The following is a description of a gene set: studied in species Homo sapiens Genes predicted to be targets of miRBase v22 microRNA hsa-miR-98-5p in miRDB v6.0 with MirTarget v4 prediction scores > 80 (high confidence targets). from publication Chen Y, Wang X (PMID 31504780) Human Gene Set: MIR98_5P, and this is the list of marker genes: NME6, SALL3, FAXC, CLCN5, SLC22A23, LIPH, NIPAL4, PBX3, TMOD2, STRBP, CPEB2, TMPPE, ITGB3, MYCN, E2F6, RGS16, ZCCHC9, CCNJ, TGFBR3, CLP1, ABL2, ERCC4, ATOSB, SENP5 (SUMO specific peptidase 5), ZNF512B, DTX4, RFX6, TMEM65, NAT8L, ARHGEF38, GALNT2, COIL, FNDC3B, KCNJ11, IMPG2 (interphotoreceptor matrix proteoglycan 2), CPA4, GATM, PRSS22, MDM4 (NCBI Gene Id 4194), FAM135A, TNFSF9, GPATCH2, LPGAT1, PIK3IP1, MEF2C, DDX19B, HOXA1, SLC5A6, PABIR1, FRAS1, HSPA14, FASLG, C14orf28, NEK3, CNTRL, CADM2, BEGAIN, CRTAM, NME4, PLEKHO1, TMC7, SRD5A3, IGF1R, GOLT1B, IKZF2 (NCBI Gene Id 51173), YOD1, ZNF280B, PEX11B, ZBP1, IGF2BP2, KLHL31, APBB3, CHD4, PRPF38B, ZNF275, RGS6, SDK1, ZNF322 (zinc finger protein 322), SALL4, NHLRC3 (NCBI Gene Id 387921), SLC25A27, NAP1L1, PAPPA, COL27A1, RICTOR (NCBI Gene Id 253260), PBX1, VCF1, ZNF784, STARD3NL, STARD13, GYG2, BEND4, POLR3D, DPH3, GABBR2, COL3A1, BIN3, HOXD1, ARID3A, ENTREP2, C15orf39, XKR8, SOCS4, MAP3K9, FNIP2, ERCC6, COL1A2, TRANK1 (NCBI Gene Id 9881), CEP135, CEP120, LRIG2, SMARCAD1, ACTA1, DVL3, ABHD17C (NCBI Gene Id 58489), HIC2, GDF6, MEIS2, ZFYVE26, SUB1, AGAP1, BACH1, ADRB2, CERT1, MFSD4A, SMC1A (structural maintenance of chromosomes 1A), THRSP, STIMATE, LIPT2, OSMR, BZW1, RAB11FIP4, HDX, PCDH19, SLC20A1, XK, PXDN (NCBI Gene Id 7837), EIF4G2, RIMOC1, GAN, AMOT, IGF2BP1, EDEM3, AHCTF1, CBX5, DHX57, KDM3A, WDR37, CD59, SLC16A9, ZNF689, DPP6 (dipeptidyl peptidase like 6), CCL7, ABCC5, PLA2G3, CNOT6L, GPCPD1 (NCBI Gene Id 56261), ZSWIM5, USP38, GALC, PALD1, SLC5A9, GALNT1, ARK2C, THOC2, SRGAP1, DUSP22, ANKRA2, XRN1, IL13, ELP1, OSBPL3, CPEB1, HAND1, COL5A2, RASGRP1, MBD2, FZD4, GCNT4, EEA1, SLC35D2, AKAP6, SCD, HMGA2, DMD, FNDC3A, CPEB3, SNX30, RAB8B, DDX19A, ACVR1C, B4GAT1, MASP1, USP44, WNT9B, MAP4K3, LIMD2, TMEM167A, TAF9B, ARID3B, ZNF710 (NCBI Gene Id 374655), POGLUT1, STX3, PPP1R15B, ACVR2A, PEG10, SLC10A7, ENTPD7, HIP1, SESTD1, DLST, TSEN34, CARNMT1, AGO4, SEMA4G, IGF2BP3, NGF, UHRF2, EEF2K, TSPEAR, COL4A1, ADAMTS8, C19orf47, PCGF3, GPR26, FNIP1, DTX2, E2F5, GXYLT1, TRIM71, ASAP1, ATL2, PLPP5, UGCG, CDC25A, NPHP3, ARMT1, MARS2, FBXL12, AMT, KLF9, PARPBP, IQCB1 (NCBI Gene Id 9657), IGDCC3, GTF2I, PRLR, CEMIP2, LAMP2, SNX16, GNG5, GJC1 (gap junction protein gamma 1), BSN, ZBTB5, AP1S1, EPHA4, LRIG3, PDE12, HIF1AN, SMIM3, OPA3, LINGO1, PLPP6, USP24, PIGA, DUSP1, COL4A6, SPRYD4, FGD6, KCTD21, LIN28B (lin-28 homolog B), ZBTB8B, CLDN12, KIAA0930, HDLBP, PTPRD, ADRB3, RSPO2, ERO1A, ABCB9, SIGLEC14, NYNRIN (NYN domain and retroviral integrase containing), DNAAF9, CD164, ERVH48-1, LIN28A, UTRN, CDKN1A, ELF4, SEMA4C, TTLL4, DNA2, GNPTAB, ZNF644, YPEL2, DIP2A, RDX, LBR, PDPR, VIRMA, SENP2, ONECUT2, HOOK1, ATP2A2, AEN, MMS22L, DCUN1D2, DNAJA2, FIGN, CDC34, ACER2, DDI2, NRAS, KCNC2 (NCBI Gene Id 3747), TMPRSS2, ZNF516, COL4A2, PTAFR, INSR, ARL5A, TGFBR1, VAV3 (vav guanine nucleotide exchange factor 3), PLXND1, TMEM121B, DLC1, TRIM67, IGDCC4, PRTG, STARD9, ACSL6, EFHD2 (EF-hand domain family member D2), MAPK6, ZNF583, ESR2, PLEKHA8, NKAPD1, PARP8, KLF8, PGRMC1, E2F2, CLDN16, SLC2A12, SLF2 (SMC5-SMC6 complex localization factor 2), ABT1, STK40, POGZ, RUFY3, HAS2, PLXNC1, SLC38A9, SCN11A, CERCAM (NCBI Gene Id 51148), RANBP2, EDN1, XYLT1, DCAF15, MIB1, CCND2, IRS2, FIGNL2, PPP1R16B, MAPK8, GFM2, RALB, FZD3, B3GNT7, POLL, NR6A1, DNAJC1, PBX2, FGF11, KCTD17, SIGLEC5, MTDH, HECTD2, KIAA1958, TET3, RBFOX2, ADAMTS15, PXT1, SLC31A2, MRS2 (magnesium transporter MRS2), RNF20, TBKBP1, ATP8B4, LEPROTL1, ARHGAP28, FRMD4B, SCN4B, ARG2 (arginase 2), SKIL, GAS7, TECPR2, PLAGL2, NPEPL1, DDTL, C8orf58, PLEKHG6, MED8, CASP3, TMEM234, KLHDC8B, MAP3K1, SFMBT1